The following is a description of a gene set: Human Gene Set: GOBP_NEURONAL_STEM_CELL_POPULATION_MAINTENANCE studied in species Homo sapiens Any process in by an organism or tissue maintains a population of neuronal stem cells., and this is the list of marker genes: FUT10, HES1, SS18, IGF2BP1, MMP24, PROX1, ASPM, FOXO3, SRRT, REST, SOX2, MCPH1, DLL1, JAG1, WDR47 (WD repeat domain 47), HOOK3, HES5, FANCD2, YME1L1, FOXO1, PRRX1, CDH2, NOTCH1, PCM1